The following is a description of a gene set: Human Gene Set: HP_ABNORMAL_CIRCULATING_CARBOHYDRATE_CONCENTRATION Abnormal circulating carbohydrate concentration studied in species Homo sapiens A deviation from the normal concentration of a carbohydrate in the blood circulation., and this is the list of marker genes: PTPN22, ITPR3, GALE, DCXR, HNF1A, SLC25A13, GALT, RPIA, IL6, SLC2A2, GALK1, SORD, GALM, TKT, GK, SKIC3